Given this list of marker genes CDH1, AAGAB, AKT1, CTNNB1, BRCA2, IDH2, PPM1D, ATR, SMAD4, PTPN6, MSH2, TP53, RAD51D, RABL3, BARD1, TGFBR2, POLD1, AXIN2, MRE11, PALLD, PALB2, NQO2, STK11 (serine/threonine kinase 11), ESR1 (NCBI Gene Id 2099), EPCAM, CHEK2, PMS1, SLC22A18, ATM, GNAS, CDKN2A, FGFR2, POLE, PHB1, RAD54L, SDHB, MSH6, NTHL1, RAD50, PRKN, PTEN, OPCML, COL14A1, CASP8, WRN, SLC6A17 (NCBI Gene Id 388662), NF1, KLLN, SDHD, PIK3CA, RAD51C, RAD51, SDHC, KRAS, BRIP1, RB1CC1, NBN, PMS2, ERBB2, USF3, BRCA1, RNF43, XRCC3, IDH1, APC, HMMR, MDM2, TWIST1 (NCBI Gene Id 7967), MLH1, MEFV, SEC23B, here is a description of the gene set: Breast carcinoma The presence of a carcinoma of the breast. Human Gene Set: HP_BREAST_CARCINOMA species: Homo sapiens